The following is a description of a gene set: studied in species Homo sapiens Neighborhood of IL4 Neighborhood of IL4 interleukin 4 in the MORF expression compendium Human Gene Set: MORF_IL4, and this is the list of marker genes: ATP10B, MLLT10, CPB2, IFNA1, RYR3, GPR15, SLC46A3, ECM2, COL19A1, PAX7, DNAJC22, CDC73, COL8A1, CCR3, CA3, PHOX2B, ADAMTSL3, PDE4D, GNG4, ANXA10, CTSB, EXOC4, MAGEA9, TBX19, THRA, SPRR2C, KRT34, EDN3, OR10H3, ZNF202, SLC16A5, APOBEC1, CCN6, SLC17A7, NHEJ1, ITGBL1, MDM2, RAC3, SFRP4, SULT4A1, AIM2, FGF2, PLPPR4, GCA, NTNG2, ZNF157, RB1CC1, GLRA3, LDB3, TLL1, ATXN3, IFNW1, TNIK, PLXNA3, ZNF132, MAGEA8, PVR, RAD51D, HOXB7, PDCD1, ENOX2, SOCS6, GJB5, OTC, SERPINA4, SLC15A1, JRKL, ATP2B2, HCRTR2, LRP4, ABCB1, NR3C2 (NCBI Gene Id 4306), ATF6B, MPZL1, ABO, LILRA4, PCDHB17P, C6, SLC14A2, PHF10 (PHD finger protein 10), SUPT3H, CAMK4, TENM4, OR2B6, PSD (pleckstrin and Sec7 domain containing), CDKL5, CCL16, HNF1A, AKAP3 (NCBI Gene Id 10566), NCKIPSD, MAP2K6, ATP4B, NEB, P2RY10, PNLIPRP2, RNF24, LECT2, TRIO, KLRC4, NOS2, KCNA5, LILRA1, STXBP5L, GABRB2, DRC3, BRD4, FZD5, MAP2K7, SOAT2, DGCR5, IL4, FSHR, SEMA6A, NPAS2, PAX6, IFNA14, CRHR1, TSPYL1, TBXT, UBE4B, IL3, PDE6A, IL7, COLGALT2, MPP3, CSRP3, ADAM20, FOSL1, LGI1, PCM1, F2RL1, CDH8, DOK5, B4GALT6, MID2, ATP8A2, FGA, ELL2, ZBTB14, CCIN, GRIK1, ATF2, GPR171, HOXC11, CADM4, SLC6A4, IPO9, PSG1 (pregnancy specific beta-1-glycoprotein 1), SRPK3, CEP162, SIX6, THPO, RBMS3, PART1, RXRG (NCBI Gene Id 6258), NPFF (NCBI Gene Id 8620), PHLDB1 (NCBI Gene Id 23187), CMKLR2, DEPDC5, ZSCAN26, DRD1, PPM1E, MAGI1, GCM1, EDIL3 (NCBI Gene Id 10085), GZMH, MINDY2, JADE3, HTR1E, TNK1, GPR19, ROR2, VIP, REPS2, DMD, CALN1, KRT2, SLC6A2, AMMECR1, STAC, MYH2, CDH4, ST8SIA1, TACC2, POLR1HASP, PTPRS, KPNA1, TTTY1, ATP8B1, POU6F2, RSC1A1, SLC17A1